Given this list of marker genes Klhl13, Dlg4, Hes6, Npy2r, Lhx2, Ceacam1, Arpc5l, Alcam, Sgk3 (serum/glucocorticoid regulated kinase 3), Slc7a14, Ubqln2 (ubiquilin 2), Rnf222, Nfkbiz, Itga4, Grpel2, Trappc10, Eif4e, Nlgn2 (neuroligin 2), Lrrc4, Kpna3, Bmp2k, Ctbp2, Prx, Gpr88, Fbxw26, Mrpl42, Tmed7, Sim1, Lhfpl6, Phf20, Ttc1, Ceacam2 (CEA cell adhesion molecule 2), Cabin1, Il5ra, Fbxw2, Hectd1, Exoc5, Glb1l, Acsl1, Hand2, Id2 (inhibitor of DNA binding 2), here is a description of the gene set: Mouse Gene Set: MIR_7658_3P from publication Chen Y, Wang X (PMID 31504780) Genes predicted to be targets of miRBase v22 microRNA mmu_miR_7658_3p in miRDB v6.0 with MirTarget v4 prediction scores > 80 (high confidence targets). studied in species Mus musculus